The following is a description of a gene set: studied in species Mus musculus Mouse Gene Set: GOBP_CELL_CELL_JUNCTION_ASSEMBLY The aggregation, arrangement and bonding together of a set of components to form a junction between cells., and this is the list of marker genes: Cd9, Cgn, Cldn34c5, Cldn18, Trpv4, Nphp1, Cdh20, Srf, Cldn34c1, Pkn2, Rhoa, Abi2, Cntnap2, Agt, Ctnnb1, Ptpro, Slc39a9, Irx3, Ctnna1, Pecam1, Cdh18, Marveld3, Cdh6, Cldn16, Cdh12, Ildr1, Fkrp, Hopx, Ocln, Aplnr, Cldn34c2, Cldn12, Cdh4, Myo1c, Nfasc, Hdac7, Cldn23, Mpdz, Cdh2, Rock1, Cldn34a, Cldn3, Jup, Cldn5, Tbcd, Cldn14, Fbf1, Cldn10, Rps6, Gjd3, Prkca, Cldn34d, Vcl, Marveld2, Jam3, Fer, Ace2, Rhoc, Cdh5, Il17a, Snai1, Ect2, Rock2, Cdh13, Afdn, Cdh15, Gjb6, Cdh1, Cldn17, Grhl2, Itgb1, Fzd5, Wnt11, Cldn34b4, Cdh19, Nr1h4, Aloxe3, Gnpat, Cldn2, Cdh9 (NCBI Gene Id 12565), Pard3, Prkaca, Fscn1, Ramp2, Smad7, Cldn34b1, Gjc1, Il1b, Ocel1, Frmpd2, Cdh17, Ace, Samt2, Esam, Cldn1, Cldn8, Cdhr18, Ephb2, Acvrl1, Pkp1, Gjb2, Cldn34c6, Gja5, Cldn19, Cldn24, Cldn34c3, Samt4, Rab13, Rps6-ps4, Cdh11, Cdh7, Cldn4, Flcn, Cav1, Prkcz2, Tjp1, Pkp2, Mpp7, Actb, Samt3, Actg1, Cdh8, Cldn9, Gpbar1, Cldn6, Arl2, Cldn34b2, Samt2b, Gdf2, Actn4, Dlg1, Nedd4l, Cldn34c4, Cldn22, Patj, Cldn7, Pkp4, Nphs1, Samt1d, Nphp4, Gja1, Lsr, Alox12b, Pak2, Zfp703, Dlg5, Tnf, Pmp22, Cntnap1, Pof1b, F11r, Tbx5, Pdcd6ip (NCBI Gene Id 97504), Cldn13, Epha2, Dsg3, Micall2, Hipk1, Pkp3, Snai2, Cldn15, Cdh3, Ikbkb, Cldn34b3, Epb41l3, Cdh22, Ugt8a, Cldn11, Cdh10, Cdh26, Prkch, Wdr1, Samt1b (spermatogenesis associated multipass transmembrane protein 1b), Rac1, Cdh24